The following is a description of a gene set: Abnormal T-wave An abnormality of the T wave on the electrocardiogram, which mainly represents the repolarization of the ventricles. Human Gene Set: HP_ABNORMAL_T_WAVE species: Homo sapiens, and this is the list of marker genes: AKAP9, CLCNKB, NOS1AP, HCN4 (NCBI Gene Id 10021), ALG10B, SCN5A, SLC1A3, KCNQ1, MECP2, CACNA1A (calcium voltage-gated channel subunit alpha1 A), CAV3, SCN4B, KCNH2, PRKAG2, JUP, TRDN, GYG1 (glycogenin 1), CALM1, CALM3, SLC12A3, TBX5, SNTA1 (syntrophin alpha 1), KCNJ2, KCNE2, MYL3, ANK2, ATP1A3, KCNJ5, RYR1, KCNE1, ATP1A2, SCN10A, CACNA1C, DCAF17, CALM2, BRF1, MYL2